The following is a description of a gene set: Human Gene Set: GOBP_REGULATION_OF_STEROID_BIOSYNTHETIC_PROCESS studied in species Homo sapiens Any process that modulates the frequency, rate or extent of the chemical reactions and pathways resulting in the formation of steroids, compounds with a 1,2,cyclopentanoperhydrophenanthrene nucleus., and this is the list of marker genes: GFI1, NR3C1, POR, FGF1, PRKACA, WNT4, DHH, PAQR3 (progestin and adipoQ receptor family member 3), CGA, MIR98, LPCAT3, IGFBP7 (NCBI Gene Id 3490), ERLIN1, MIR182, BMP5, ABCG4, BMP6, GGCX, APOB, FSHB, MIR342, FGF19, SREBF2, ATP1A1, PDE8B, ASAH1, INSIG1, ABCG1, BGLAP, NR1H4, C7orf50, AKR1C3, DDX20, QKI, NR0B1, AQP8, ABCA2, MIR548P, LHCGR, TNF, DGKQ, CREB1, PRKG1, IFNG, SEC14L2, MIR185, MBTPS1, DKK3, SIRT1, BMP2, SREBF1, EGR1, SNAI1, LEP, CES1, SCAP, CYP7A1, PRKAA1, H6PD, NR1D1, DAB2, NFKB1, TSPO, ADM, MBTPS2, FGFR4, PROX1, GNAI1, MALRD1, MIR33A, NR5A2, SNAI2, APOE (NCBI Gene Id 99), DKKL1, CLCN2, MAPK1, ERLIN2, MIR30C1, ARMC5, GPR146, KPNB1, STAR (steroidogenic acute regulatory protein), MIR96, STARD4, REST, INSIG2, GPRC6A, NR5A1